Given this list of marker genes Ppa1, here is a description of the gene set: Reactome Pathway: Cytosolic tRNA aminoacylation electronically inferred by orthology from the curated human pathway This event has been computationally inferred from an event that has been demonstrated in another species.<p>The inference is based on the homology mapping from PANTHER. Briefly, reactions for which all involved PhysicalEntities (in input, output and catalyst) have a mapped orthologue/paralogue (for complexes at least 75% of components must have a mapping) are inferred to the other species. studied in species Mus musculus part of: tRNA Aminoacylation